Given this list of marker genes Igf1, Frs2, Esr1, Rxra, Notch1, Trp63, Wdr77, Foxa1, Hoxd13, Sfrp1, Fgfr2 (NCBI Gene Id 20946), Hoxb13 (homeobox B13), here is a description of the gene set: Mouse Gene Set: GOBP_PROSTATE_GLANDULAR_ACINUS_DEVELOPMENT The progression of a glandular acinus of the prostate gland over time, from its initial formation to the mature structure. The glandular acini are the saclike structures of the gland. studied in species Mus musculus